The following is a description of a gene set: HBV LHBs to PKC-ERK signaling pathway. Pathway ID: N00547. Pathway type: Pathogen. Pathway class: nt06263 Hepatocellular carcinoma. Human Gene Set: KEGG_MEDICUS_PATHOGEN_HBV_LHBS_TO_PKC_ERK_SIGNALING_PATHWAY species: Homo sapiens Pathway Definition from KEGG: S -> PKC -> RAF -> MEK -> ERK -> AP1, and this is the list of marker genes: PRKCA, MAPK1, MAP2K1, MAP2K2, PRKCB, JUN, MAPK3, ARAF, PRKCG, FOS, RAF1, BRAF (B-Raf proto-oncogene, serine/threonine kinase)